The following is a description of a gene set: To identify signature genes that help distinguish (1) sepsis from non-infectious causes of systemic inflammatory response syndrome, (2) between Gram-positive and Gram-negative sepsis. Human Gene Set: GSE9960_GRAM_POS_VS_GRAM_NEG_AND_POS_SEPSIS_PBMC_DN Genes down-regulated in peripheral blood monocytes (PMBC): Gram positive sepsis versus mixed infection sepsis. studied in species Homo sapiens from publication Payen D, Lukaszewicz AC (PMID 19535937), and this is the list of marker genes: PTPN23, RDH11, SLC25A20, EZR, KRTAP3-1, RASAL1, GLI2, REG1A, H2AZ1, SH3BP5, HIVEP1, SMARCAD1, FMNL3, PRDM1, EMP3 (epithelial membrane protein 3 (MAM blood group)), FLOT2, SLC9A8, EEA1, CEL, LRP10, PICK1, ZNF841, MFSD1, PTGES2, VPS37B, PNMT, OLR1, VSX2, ADORA2B, GPR162, GJA10, METAP1, TOP2A, BCL2L11, RAB10, MME, STX12, CDC6, EYA4, FBXL3, RIOK3, CLDN3, PAH, CYP17A1, LCN2, VAMP1, PNLIPRP1, H2BC5, RNASE1 (NCBI Gene Id 6035), CHST3, EIF4E, CYTH3, CAPZA1, CTRB2, ERO1A, ATP1B3, LIFR, RNF14, RPS6KB1, TXK, ADORA2A, DTX2, KMT5A, REG1B, UBR4, HMGB3, ZNF131, RHAG, SFR1, CLEC4E, CTRL, APOBEC2, VAMP7, TNIP1, ALAS2, NCF4, WFDC2, FAM110A, PER2, FOXH1 (NCBI Gene Id 8928), MET, KLK6, ABCC1, PTEN, ATOH1, REG3A, BGN, CARD19, BIRC3, ID2, LIG1, ITGA5, MKI67, SYCN, RAB8B, MSL2, WDR45B, TUBA1C, PTCH1, CDC42EP4, PIPOX, GRIN2B, MIF4GD, BATF, PRELID3B, ACP3, DDX25, KLC2, CTSG, NCF1, HGD, CTNNB1, UTY, NAB1, GNRHR, ZC3H12C, IL36RN, SRA1, LBP, AK2, CUZD1, ARL2BP, KCNN4, MNAT1, TMBIM1, WNT11, EHD1, TUBB4B, GABPB1, NKAIN1, PPP1R2P1, STK11IP, SURF4, SLC4A4, NEUROD4, MXD1, NFKBIE, EPHX2, PTGIR, IL1A, TEAD1, AMFR, RASGRF1, REG3G, C19orf53, AMY2A, SULT2B1, GPR132, H1-2, CD44, CCL21, DMBT1, CLPS, PLEKHA1, SCN9A, STXBP3, MTMR7, JARID2 (jumonji and AT-rich interaction domain containing 2), C9orf72, ZG16, BAIAP2 (NCBI Gene Id 10458), TAB3, MAP7, RASIP1, DPF3, RPS6KA4, HSD11B1, A2M, GRPR, RRS1 (ribosome biogenesis regulator 1 homolog), TRIM13, NFKB2, FOXN3 (forkhead box N3), NMRK1, FPR1, ST6GALNAC1, LRPAP1, GHRL, LRG1, HIVEP2, BCL3, DTL, RANBP10, CDC73, ZBTB7A, PXN, GNAZ, CDCA4, CELA2A, CYP27B1, ITPKB, SIPA1L2, HP, SLC12A1, MXI1, FAM50B, KRTDAP, HPCAL1, ID3, WBP4